The following is a description of a gene set: Z-decay: degradation of maternal mRNAs by zygotically expressed factors Human Gene Set: REACTOME_Z_DECAY_DEGRADATION_OF_MATERNAL_MRNAS_BY_ZYGOTICALLY_EXPRESSED_FACTORS studied in species Homo sapiens, and this is the list of marker genes: TUT7, EIF4B (eukaryotic translation initiation factor 4B), EIF4A2, EIF4A3, EIF4E, TUT4, PAIP1, EIF4A1, EIF4G1, PABPN1, DIS3L2, PABPC1